The following is a description of a gene set: The directed movement of substances, in membrane-bounded vesicles, from the early sorting endosomes to the recycling endosomes. studied in species Homo sapiens Human Gene Set: GOBP_EARLY_ENDOSOME_TO_RECYCLING_ENDOSOME_TRANSPORT, and this is the list of marker genes: MYO1D, RAB11FIP3, RAB11A (RAB11A, member RAS oncogene family), DNAJC13, CORO1A, SORL1, DYNC1LI1